Given this list of marker genes Abcc5, Hexa, Chpf, Chpf2, Dse, Chil4, Idua, Cd44, Igf1, Pglyrp1, B3gnt2, B3gnt4, Tgfb1 (transforming growth factor, beta 1), Il1b (NCBI Gene Id 16176), Sgsh, Has3, Pglyrp3, B4gat1, Hs3st3a1, Cytl1, Pdgfb, Arsb, Cemip, B3gnt6, Ap2a1, Itih4, Ovgp1, Chil3, Chil5, Ccnd3, Ugdh, Cltc, Dsel, Ids, Galns, Hs3st3b1, B3gnt3, Chst13, B4galt7, Fgf2, Xylt2, Hyal1, Gusb, Galnt3, B3gat2, Cln6, Chsy1, B3gnt8, Chst11, Hyal3, Pglyrp2, Csgalnact1, Chst3 (NCBI Gene Id 53889), Egf, Has2 (NCBI Gene Id 210441), Hyal4, Pxylp1, Slc9a1, Naglu, Has1, Pglyrp4, Hexb, Chil6, Slc35d1, Itih3, Ptger4, Chit1, Hyal6, Chst7, Tnfaip6, Itih1, Chia1, B3gnt7, Cemip2, Ext1, Hs3st1, B4galt5, Lyg1, Itih2, Stab2, Hmmr, B4galnt4, Smpd3, B3gat1, Csgalnact2, Ext2, Il15, Slc35b2, Lyve1, Spam1, Hyal2, B3gat3, Hs3st2, Ndst1, Foxc1, Habp4, Chi3l1, Pdgfrb, Lyg2, B3gnt9, B3galt6, Ctbs, Nfkb1, Itih5, Chst12, Bpnt2, B4galnt3, Ndst2, Xylt1, Chsy3, Hyal5, here is a description of the gene set: Mouse Gene Set: GOBP_AMINOGLYCAN_METABOLIC_PROCESS studied in species Mus musculus The chemical reactions and pathways involving aminoglycans, any polymer containing amino groups that consists of more than about 10 monosaccharide residues joined to each other by glycosidic linkages.